Given this list of marker genes CFHR1, CFHR3, HMCN1 (NCBI Gene Id 83872), IMPDH1, HGSNAT, NMNAT1, APOE, here is a description of the gene set: Human Gene Set: HP_GEOGRAPHIC_ATROPHY Sharply demarcated area of partial or complete depigmentation of the fundus reflecting atrophy of the retinal pigment epithelium with associated retinal photoreceptor loss. The margins of the de-pigmented area are usually scalloped and the large choroidal vessels are visible through the atrophic retinal pigment epithelium. Geographic atrophy species: Homo sapiens